Given this list of marker genes ZNF257, HAT1, TRIM10, MAP3K2, BTAF1, OLFM4, GAB2, PLAGL2, CADM1, ZNF331, PYCR2 (pyrroline-5-carboxylate reductase 2), NLRP1, DYNLL1, ARHGAP5, DCC, LCE3E, ABHD17B, CTDSPL2, PTEN, PTPN12, FGF7, ADAMTSL1, ATXN7L3, C19orf73, SNRPD1, AFF3 (NCBI Gene Id 3899), MARK1, COPS7B, NCKAP5, CSPG5 (NCBI Gene Id 10675), SMOC1, NR2F1, ZNF268, TRNT1, BCL11B, DARS1, ARID4B, BCAS2, AREG, FOXP1, SLC10A7, VTCN1, TSC22D2, FAHD1, NR2C2 (NCBI Gene Id 7182), RBPJ, MRPL47, GCNT2, MCMDC2, GABRB3, FOXO1, CELF2, MXI1, ARHGAP44, CDH7, UBASH3B, SRSF3, NUDCD1, DENND2B, ERFE, TXLNG (NCBI Gene Id 55787), NUDT11, LILRB4, CEMIP, DOCK3, STK26, PRRC2C, WSCD1, GPX8, GPR153, BIRC6, SP5, CCDC85C, COPG2, CNTNAP4, PIK3AP1, NEUROD6, LMTK2, CDK4, COL6A6, CD247, RELT, CNKSR2, SERPINE1, CREBRF, PIK3R1, MRTFA, LINGO4, IGF1, MYLK2, SLC12A5, ULK2, TRIM36, TOB1, here is a description of the gene set: from publication Chen Y, Wang X (PMID 31504780) Genes predicted to be targets of miRBase v22 microRNA hsa-miR-486-5p in miRDB v6.0 with MirTarget v4 prediction scores > 80 (high confidence targets). species: Homo sapiens Human Gene Set: MIR486_5P